The following is a description of a gene set: species: Homo sapiens Human Gene Set: KAECH_NAIVE_VS_MEMORY_CD8_TCELL_UP How and when memory T cells form during an immune response are long-standing questions. To better understand memory CD8 T cell development, a time course of gene expression and functional changes in antigen-specific T cells during viral infection was evaluated. The expression of many genes continued to change after viral clearance in accordance with changes in CD8 T cell functional properties. Even though memory cell precursors were present at the peak of the immune response, these cells did not display hallmark functional traits of memory T cells. However, these cells gradually acquired the memory cell qualities of self-renewal and rapid recall to antigen suggesting the model that antigen-specific CD8 T cells progressively differentiate into memory cells following viral infection. Genes up-regulated in naïve CD8 T cells compared to memory CD8 T cells (day 40+ after LCMV-Armstrong infection). from publication Kaech SM, Hemby S, Kersh E, Ahmed R (PMID 12526810), and this is the list of marker genes: OXCT1, CRY1, DAP, NSMCE1, EXT1, SLC39A1 (NCBI Gene Id 96436, solute carrier family 39 member 1), SFXN2, PIP4K2A, METTL9, ACTN1, IKBKE, RFLNB, PAN2, EPHX1, RAB3IP, CCR9, HDAC2, CRAMP1, DUSP16, CALU, ANKRD10, GTF3C1, AKAP9, MFHAS1, CXXC5, SLC30A4, RPL22L1, RALGPS2, PRKCB, ZFR, NEDD9, MRM3, MYB, ARL8B, TUBA1A, TCF4, USP34, TTC3, WDR26 (NCBI Gene Id 80232), COL5A1, RCAN3, HLA-DOB, DICER1, NCF2, PRKD2, TIA1, WNK1, HLA-DOA, KLF7, LAMP2, CNN3, ADCY7, SPTBN1, ORC4, RWDD4, FKBP4, PWP1, TMEM50B, UBE2R2, SQOR (sulfide quinone oxidoreductase), ITGAE, MIA3, NRAS, NAP1L1, NCBP1, SPSB1, MXD4, PAPOLA, ZFAND5, PSAP, RERE, WASHC3, HDLBP, SESN1, CD5, CDK2, IL6R, DAG1, RPS8, TMEM245, SFMBT2, GRK6, TTC14, ATP5IF1, SPCS2, SMPD2, PPIC, ZNF281, CASK, RAMP1, ZNF292, CCDC28B, FADS1, PHTF2, IFI27L2, RETREG1, GPD2, ISG20, ZPBP, INTS14, NAB2, ZNRF1, PRM2, TDRP (NCBI Gene Id 157695), SMC4, ATAD2B, ABLIM1, IRF9, SQLE, ST13, MECR, POU2AF1, CANX, BIRC3, MAP7, HDAC1, KIF23, KMT2A, RBX1, CDK16, NSG2, RGS10, ANAPC5, PLEKHA1, MPHOSPH9, ENG, TMEM191C, IL6ST, IDH2, BLK, DNAJC7, FCER2, BTBD1, CSNK1E, RGS7, ANP32A, FARSB, CYB5A, PTOV1, KANSL2, PBX2, RPS2, MBTD1, ZFP1, RNF14, JARID2, CSAD, NRIP1, BIRC2, EPHA5, EGR2, TLR6, TNFAIP8L1 (NCBI Gene Id 126282), CD1D, MIOS, IGF1R, MGST2, GATA2, ACADM, PDK1, DUSP6, NDRG1, IFIT1B, S100PBP, STT3B, CLK4 (NCBI Gene Id 57396), TSPAN32, RNASET2, LDLR, TNNT1, UGCG, PSMA5, PATJ, ID3, CCR7, ABCG2, ZBTB2, CYTH3, CD79B, MAP4K2, AHR, GABRR2, GGT5, ETS2, DNTT, DDIT4, WFS1, ST6GAL1, ADCY6, TRIM21, CD9, CD8A, IGHM, GRIA3, SRCAP, ANKFY1, MS4A1, MPP1, RPF1, SEC11C